The following is a description of a gene set: Mouse Gene Set: GOBP_REGULATION_OF_BODY_FLUID_LEVELS species: Mus musculus Any process that modulates the levels of body fluids., and this is the list of marker genes: Htr4, Cel, Ctns, Mmrn1, Alox12b, Ttr, Scnn1b, Tifab, Prl2b1, Oprk1, Adra2b, Enpp1, Angpt2, Adrb1, Hk2, Aqp4, Egfr, Gna13, Klkb1, Itgb3, Fgb, Prl8a6, Atp7b, Hps6, Stk39, Lyn, Gnas, Lnpk, Pip5k1c, Prickle1, Tspan9, Agr2, Zbtb7b, Adora1, Gas6, Foxb1, Anxa5, Adrb2, Tfpi, Med1, Gata1, Tubb1, Prl7c1, Ptprj, Tph1, Vtn, Hgfac, Mertk, Ppia, Fzd6, Prl7d1, Ano6, F2rl1, Map1lc3b, Tpsab1, Celsr2, Nlrp6, P2ry1, Avp, Serping1, Adora3, Alox12, Prl8a9, Neurog1, Adamts13, Slc5a2, Pdgfra, Nfat5, Anxa8, Aqp2, Ptger3, Vdr, Aqp7, Ccnd1, Bpifa5, mt-Co2 (mitochondrially encoded cytochrome c oxidase II), Pdia6, Procr, Aqp5, Prkca, Rap2b, Wnk3, Kcnma1, Serpind1, Prrg2, Psg23, Ddr1, Plat, Trpc1, Prkcq (protein kinase C, theta), Plau, Aplnr, Ada, Ptger4, Copa, Mpig6b (NCBI Gene Id 106722), Foxa2, F10 (NCBI Gene Id 14058), Tspan32, Srf, Vamp8, Adra2c, Pdgfb, Anxa2, Sytl2, Oas2, Il6, Fgg, Serpina10, Tmprss6, Tfpi2, Coro2b, Prl7b1, Fermt3, Evl, Ubash3b, Cad, Gp1bb, Angpt1, Hnf4a (NCBI Gene Id 15378), Adora2a, Pdpn, Umps, Hyal2, Hps4, Eif2ak3, F5 (NCBI Gene Id 98271), Ubash3a, Cyba, Ext1, Clcnka, Ano1, Prl3d1, Dtnbp1, Gnaq, Prl3c1, Bloc1s3, Akr1b1, Rab14, Ephb2, Wnk1, Tec, Csn3, Prl, Creb1, Abcb1a, Csn2, P2ry2 (NCBI Gene Id 18442), Enpp4, Tyro3, Axl, Vps33b, Slc6a3 (NCBI Gene Id 13162), Prl7a1, Xbp1, Prss56, Bloc1s6, Hrg, Entpd1, Angptl7, Ednrb, Prkg1, Tspan18, Uts2, Mmp13, Aqp6, Cd9, Erbb4, Rplp0, Apln, F13b, Vwf, Uts2r, Nfe2l2, Tbxa2r, Slc4a5, Cyp11b2, Vkorc1, Stat5b, Prkcd, C1galt1c1, Prl4a1, Tlr4, Sh2b3, Prrg3, Tac4, Prl2c5, F11, Ceacam1, Slc6a4, Nbeal2, F12, Prl3d2, Pdia3, Slc7a11, Trpv5, Stxbp1, Atp6v1b1, Mllt6, Serpinc1, Inpp5k, Fosl2, Hif1a, Socs2, Kng1, F2rl3, F2r, Slc29a1, Stat5a, F11r, Shh, Chrm3, Il6ra, Cdo1, Trp73, Wnt3a, Wnk4, Fgf10, Fga, Papss2, Aprt, Cd40lg, Trpv4, Uprt, Cftr, Syk, Stxbp3 (syntaxin binding protein 3), P2ry12, Kcnn4, Prrg4, Oprl1, Gp9, Adamts18, Ptpro, F2rl2, Proz, Scnn1g, Mfsd2b, Lilrb4a, Adtrp, Hps5, Hpse (NCBI Gene Id 231508), Prl8a8, Gnai2, Zfp385a, F9, Edn1, Treml1, Avpr2 (arginine vasopressin receptor 2), Kng2, Pla2g4a, Angptl1, Scnn1a, Fcer1g, Usf2, Cav1, Pik3cb, Atg7, Selp, Angpt4, F7, Nr3c2, Nr1h3, Fundc2 (NCBI Gene Id 67391), Flna, Prl8a2, Muc2, Svep1, Wfs1, Htr2a, F8, Prl3a1, Adm, Slc4a1, Sct, Prl2c3, Serpine1, Plaur, Rab27a, Oxt, Fgl1, Rasa3, C1qtnf1, Gja5, Bloc1s4, Plg, Neurl1a, Fgl2, Gp6, Cd36, Prl3d3, Lyst, Gp1ba, Aqp3, Ptpn6, Has2, Bpifa1, Emp2, Prl8a1, Gp5, S100a9, Prlr, Angptl2, Hsd11b2, Prrg1, Npr3, Madd, Btc, Prl3b1, Ext2, Atp2b2, Xdh, Apoe, Umod, Nkx2-3, Adra2a, Entpd2, Fbln1, Prl6a1, Anxa7, F3, Plek, Nme1, Prdx2, Heg1, Atg5, Ap3b1, Pdia2, Ppp3ca, Cpb2, Sctr, Ncoa1, F2, Prl2a1, Tmx1, Chuk, Itpr3, Slc4a9 (solute carrier family 4, sodium bicarbonate cotransporter, member 9), Emilin2, Cela2a, Kalrn, Nppb, Pdss2, Drd2, Traf3ip2, Prl7a2, Angptl4, Aqp1, Pf4, Gpat4, Prl2c2, Pdgfa, Thbd, Vegfa, St3gal4, Ghrhr, P2rx1, Prl5a1, Tspan8, F13a1, Akap11, Negr1, Comp, Thbs1, Gja1, Apoh, Hps1, Adcy6, Proc, Nr1h2 (NCBI Gene Id 381996), Prl2c1, Pdia4, Pear1 (platelet endothelial aggregation receptor 1), Pros1, Cfh, Gla, Serpine2, Chrm1, Serpinf2, Emilin1, Angptl6, Prkce, Jak2, Guca2b, Ctsg